Given this list of marker genes KRT1, KRT19, SOX2, KRT15, KRT9, SPRR3, KRT14, HES1, here is a description of the gene set: studied in species Homo sapiens from publication Liu T, Zhang X, So CK, Wang S, Wang P, Yan L, Myers R, Chen Z, Patterson AP, Yang CS, Chen X (PMID 16990345) Caudal-related homeobox 2 (Cdx2) has been suggested as an early marker of Barrett's esophagus (BE), which is the premalignant lesion of esophageal adenocarcinoma (EAC). However, the mechanism of ectopic Cdx2 expression in the esophageal epithelial cells and its role in the development of BE remained unclear. RT-PCR, pyrosequencing and methylation-specific PCR were used to determine expression and promoter methylation of Cdx2 in human esophageal epithelial cells (HET1A and SEG1) after treatment with 5-aza-2'-deoxycytidine (DAC), acid, bile acids and their combination. HET1A cells with stable transfection of Cdx2 were characterized for morphology and gene expression profiles with Affymetrix array. We found Cdx2 was expressed in most human EAC cell lines, but not in squamous epithelial cell lines. DAC-induced demethylation and expression of Cdx2 in HET1A and SEG1 cells, and treatment with a DNA methylating agent counteracted the effect of DAC. Treatment of HET1A and SEG1 cells with acid, bile acids or both also resulted in promoter demethylation and expression of Cdx2. HET1A cells with stable transfection of human Cdx2 formed crypt-like structures in vitro. Microarray analysis and quantitative real-time PCR showed that stable transfection of Cdx2 up-regulated differentiation markers of intestinal columnar epithelial cells and goblet cells in HET1A cells. This may be partially due to modulation of Notch signaling pathway, as western blotting confirmed down-regulation of Hes1 and up-regulation of Atoh1 and Muc2. Our data suggest that exposure to acid and/or bile acids may activate Cdx2 expression in human esophageal epithelial cells through promoter demethylation, and ectopic Cdx2 expression in esophageal squamous epithelial cells may contribute to intestinal metaplasia of the esophagus. Human Gene Set: LIU_CDX2_TARGETS_DN Genes down-regulated in HET1A cells (esophagus epithelium) engineered to stably express CDX2.